Given this list of marker genes SERPINA1, LGALS1, ALB, CHGB, GPC3, APOA5, SPP2, CST3, STC2, APOA2, LAMC1, ENAM, AFP, BPIFB2 (BPI fold containing family B member 2), IGFBP1, MSLN, VGF, APOL1, AMBN, MEPE, DNAJC3, MATN3, FBN1, LTBP1, BMP15, AHSG, MXRA8, IGFBP3, C4A, EVA1A, SPARCL1, TIMP1, GAS6, CALU (calumenin), PNPLA2, APOA1, MIA3, PCSK9 (proprotein convertase subtilisin/kexin type 9), CKAP4, SERPIND1, APOE, VCAN, TF, IGFBP5, HSP90B1, MEN1, AMTN, FSTL1, FUCA2, FGF23, IGFBP4 (NCBI Gene Id 3487), SERPINA10, SCG3, GOLM1, SPP1, FSTL3, QSOX1 (quiescin sulfhydryl oxidase 1), TGOLN2, IGFBP7, RCN1, CDH2, HRC, SERPINC1, APP, ANO8, PDIA6, FAM20C, MBTPS1, NOTUM, F5, SCG2, CCN1, PRKCSH, SDC2, MGAT4A, PRSS23, DMP1, C3, AMELX, APLP2, PROC, APOB, ITIH2, FGA, VWA1, P4HB, TMEM132A, ADAM10, CHRDL1, TNC, LAMB2, FN1, FGG, KNG1, BMP4, WFS1, PENK, SHISA5, KTN1, FAM20A, CSF1, CP, LAMB1, NUCB1, MELTF, IL6, MFGE8, here is a description of the gene set: species: Homo sapiens part of: Post-translational protein modification Reactome Pathway: Post-translational protein phosphorylation Secretory pathway kinases phosphorylate a diverse array of substrates involved in many physiological processes.